Given this list of marker genes HDAC2, MED1, WBP2, AR, SKP2, FSHR, HDAC6, PAGR1, PAK1, PARP1, SRARP, FOXA1, KMT2D, HDAC1, here is a description of the gene set: Human Gene Set: GOBP_POSITIVE_REGULATION_OF_INTRACELLULAR_ESTROGEN_RECEPTOR_SIGNALING_PATHWAY Any process that activates or increases the frequency, rate or extent of the activity of an intracellular estrogen receptor signaling pathway. species: Homo sapiens